Given this list of marker genes TMC2, KIT, WHRN, REST, STRC, CHRNA9, LHFPL5, COL11A1, HPN, ADGRV1, CHRNA10, MKKS, MYC, TMC1, KCNQ1, PTPRQ, PJVK, PDZD7, here is a description of the gene set: The series of events involved in the perception of sound vibration in which the vibration is received and converted into a molecular signal. Human Gene Set: GOBP_DETECTION_OF_MECHANICAL_STIMULUS_INVOLVED_IN_SENSORY_PERCEPTION_OF_SOUND species: Homo sapiens